Given this list of marker genes Smarcc1, Actl6b, Smarcd1, Scmh1, Ring1, Arid1a, Ep300, Cbfb, Bmi1, Smarcb1, Phc1, Yaf2, Cbx8, Cbx2, Cbx6, Csnk2b, Smarca2, Cbx4, Smarcc2, Smarca4, Smarcd2, here is a description of the gene set: electronically inferred by orthology from the curated human pathway part of: Transcriptional regulation by RUNX1 This event has been computationally inferred from an event that has been demonstrated in another species.<p>The inference is based on the homology mapping from PANTHER. Briefly, reactions for which all involved PhysicalEntities (in input, output and catalyst) have a mapped orthologue/paralogue (for complexes at least 75% of components must have a mapping) are inferred to the other species. studied in species Mus musculus Reactome Pathway: RUNX1 interacts with co-factors whose precise effect on RUNX1 targets is not known